The following is a description of a gene set: Human Gene Set: GOBP_BONE_MINERALIZATION_INVOLVED_IN_BONE_MATURATION studied in species Homo sapiens The deposition of hydroxyapatite, involved in the progression of the skeleton from its formation to its mature state., and this is the list of marker genes: BMP2, LTF, CCDC154, RFLNB, PHOSPHO1, IFT80, ACTN3, GREM1, LEP, SNX10, IGF1, PTH, RFLNA